Given this list of marker genes Zdhhc2, Grip2, Dlg4, Crkl, Agrn, Cd81, Mesd (NCBI Gene Id 67943), Tnfaip6, Lrp4, Rac1, Farp1, Dok7, Crk, Snx27, Musk, Ptn, Fnta, Lrp5, Ssh1, here is a description of the gene set: Any process that activates or increases the frequency, rate or extent of receptor clustering. species: Mus musculus Mouse Gene Set: GOBP_POSITIVE_REGULATION_OF_RECEPTOR_CLUSTERING